Given this list of marker genes CLK1, EFNB3, MTOR, MAP2K4, DSTYK, TEK, CAMKK2, IGF2, DYRK1A, KDR, EPHB2, DDR1 (NCBI Gene Id 780), TTBK1, ABL2, INSR, AFAP1L2, MAP2K2, FGFR4, IBTK, CLK3, PTPRC, ALKAL2, MAP2K1, PAK2, NTRK2, MAP2K7, HCK, MATK, ERBB3, DUSP3, JAK2, HIPK4, ITK, EFEMP1, TYRO3, ROR2, EPHA2, WEE1, PRKCD, HIPK1, IGF1R, SOCS3, ALKAL1, GREM1, TGFA, EIF2AK2, TTK, FER (NCBI Gene Id 2241), ERBB2, JAK3, CSF1R, DYRK3, TNK2, TESK2, PKM, ABL1, EPGN, FGFRL1, FGFR2, EPHA8, JAK1, SRMS, EPHB3, BLK, CLK4, AREG, LCK, SYK, FGFR1, NGF, KIT, CAV1, CCL5, IGF1, ROS1, DDR2, MERTK, LYN, AATK, BTK, SRC, PEAK1, PTK6, ZAP70, RACK1, MET, ABI1, STYK1, VEGFA, EGF, INSRR, FGR (NCBI Gene Id 2268), HIPK2 (homeodomain interacting protein kinase 2), PDGFRB, PTK2B, NRP1, PDGFRL, TTN (titin), MUSK, CRIM1, LTK, HBEGF, IL6ST, BAZ1B, EPHB1, DYRK4, RET, MST1R (NCBI Gene Id 5755), ERCC6, ALK, ANGPT4, EPHA3, TIE1, GRM5, EPHB6, EFNA4, EPHA5, EFNA3, ERBB4, PTK2, EPHA7, NTRK3, CLK2, EPHA1, FLT4 (fms related receptor tyrosine kinase 4), PBK, GHRL, GHR, LILRB4, NRG1, HYAL2, DGKQ, EIF2AK3, WEE2, DUSP22, CEP43, TESK1, MAP2K6, TEC, RIPK2, FYN, FLT1, CHKA, TYK2, YES1, HTR2A, MAP2K3, STAP1, RYK, NTRK1, FRK, FLT3, HIPK3, EFNA5, FES, NRG3, PKN2, MAP2K5, BTC, FGFR3, ROR1, PDGFRA, RPS6KA5, CSK, NRP2, TNK1, EPHB4, CD24, STK16, MELK, TWF1, EPHA4, AXL, IGF2R, TXK, BMX, NEK1, DYRK1B (dual specificity tyrosine phosphorylation regulated kinase 1B), EREG, PKDCC, EPHA6 (EPH receptor A6), BCR, EGFR, EPHA10, DYRK2 (dual specificity tyrosine phosphorylation regulated kinase 2), here is a description of the gene set: Human Gene Set: GOMF_PROTEIN_TYROSINE_KINASE_ACTIVITY Catalysis of the reaction: ATP + a protein tyrosine = ADP + protein tyrosine phosphate. species: Homo sapiens